The following is a description of a gene set: Gonadal neoplasm A tumor (abnormal growth of tissue) of a gonad. Human Gene Set: HP_GONADAL_NEOPLASM species: Homo sapiens, and this is the list of marker genes: WRN, CHEK2, PTCH2, DICER1, FLI1, RAD50, PMS2, CDKN1B, EPCAM, BRCA1, ZFPM2, MC2R, PAX6, KANSL1, BARD1, MSH6 (NCBI Gene Id 2956), KCNQ1, PIK3CA, CDKN1C, HNF1B, KCNQ1OT1, CREBBP, CCND1 (NCBI Gene Id 893), PTEN, NR5A1, CDKN2A, PALB2, MSH2, TXNRD2, MRAP, FGFR2, GATA4, EWSR1 (EWS RNA binding protein 1), STS, IDH2, CDH1, PTCH1, KIT, MSH3, BMPR1A, STAR, BCL10, WNT10A, RAD51, CDC73, NR0B1, NNT, MBD4, CYP11B1, PRKN, SRY, APC2, POLD1, STAG3, TP53, RAD51C, KRAS, RAD51D, PALLD, SEMA4A, POLE (DNA polymerase epsilon, catalytic subunit), MNX1, ATM, FOXE1, FGFR3, NSD1, WWOX, ZFTA, OPCML, AKT1, WT1, SETBP1, PRKAR1A, MDM2, VHL, BRIP1, ERBB2 (NCBI Gene Id 2064), DHH, NBN, LMNA, AR, STK11, PDE11A, MLH1, RNF43, RPS20, DHX37, BRCA2, SUFU, SOX9, CTNNB1, IDH1, MRE11, IGF2, MUTYH, KEAP1, VAMP7, SPRED1, SMAD4, PMS1 (NCBI Gene Id 5378), RABL3, MAP3K1, TGFBR2, EP300